The following is a description of a gene set: Loss of subcutaneous adipose tissue in limbs Loss (disappearance) of previously present subcutaneous fat tissue in arm or leg. studied in species Homo sapiens Human Gene Set: HP_LOSS_OF_SUBCUTANEOUS_ADIPOSE_TISSUE_IN_LIMBS, and this is the list of marker genes: ZMPSTE24, POLD1, LMNA, CAV1, LMNB2, PPARG, LIPE, PCYT1A, CIDEC, PLIN1